The following is a description of a gene set: studied in species Mus musculus A fatty acid beta-oxidation pathway in which the initial step, which converts an acyl-CoA to a trans-2-enoyl-CoA, is catalyzed by acyl-CoA oxidase; the electrons removed by oxidation pass directly to oxygen and produce hydrogen peroxide, which is cleaved by peroxisomal catalases. Fatty acid beta-oxidation begins with the addition of coenzyme A to a fatty acid, and ends when only two or three carbons remain (as acetyl-CoA or propionyl-CoA respectively). Mouse Gene Set: GOBP_FATTY_ACID_BETA_OXIDATION_USING_ACYL_COA_OXIDASE, and this is the list of marker genes: Acaa1b, Acox3, Crat, Acox1, Acaa1a, Hsd17b4, Acox2, Ehhadh, Acoxl